The following is a description of a gene set: from publication Houstis N, Rosen ED, Lander ES (PMID 16612386) Mouse Gene Set: HOUSTIS_ROS Insulin resistance is a cardinal feature of type 2 diabetes and is characteristic of a wide range of other clinical and experimental settings. Little is known about why insulin resistance occurs in so many contexts. Do the various insults that trigger insulin resistance act through a common mechanism? Or, as has been suggested, do they use distinct cellular pathways? Here we report a genomic analysis of two cellular models of insulin resistance, one induced by treatment with the cytokine tumour-necrosis factor-alpha and the other with the glucocorticoid dexamethasone. Gene expression analysis suggests that reactive oxygen species (ROS) levels are increased in both models, and we confirmed this through measures of cellular redox state. ROS have previously been proposed to be involved in insulin resistance, although evidence for a causal role has been scant. We tested this hypothesis in cell culture using six treatments designed to alter ROS levels, including two small molecules and four transgenes; all ameliorated insulin resistance to varying degrees. One of these treatments was tested in obese, insulin-resistant mice and was shown to improve insulin sensitivity and glucose homeostasis. Together, our findings suggest that increased ROS levels are an important trigger for insulin resistance in numerous settings. studied in species Mus musculus Genes known to modulate ROS or whose expression changes in response to ROS, and this is the list of marker genes: Prdx1, Prdx3, Mt2, Glrx2, Scaf4, Sdc4, Mt1, Txnrd1, Txn1, Txnip, Hmox1, Sod1, Prdx2 (NCBI Gene Id 98489), Txnrd2, Gpx3, Gpx5, Glrx (NCBI Gene Id 97899), Hpx, Gpx4, Hmox2, Gsr, Prdx6, Cat, Fth1, Gpx1, Cyp1b1 (NCBI Gene Id 13078), Gpx2, Xdh, Prdx4, Ftl1, Cp (NCBI Gene Id 51906), Hp, Sod3, Sod2, Gclm, Txn2 (NCBI Gene Id 80503)